The following is a description of a gene set: Any process that activates or increases the frequency, rate or extent of glutamate receptor signaling pathway. species: Homo sapiens Human Gene Set: GOBP_POSITIVE_REGULATION_OF_GLUTAMATE_RECEPTOR_SIGNALING_PATHWAY, and this is the list of marker genes: NECAB2, PRNP, CCL2, CCR2, NLGN3, IFNGR2, SHANK3, EPHB2, IFNG